The following is a description of a gene set: The regulation of the rate of heart contraction mediated by chemical signaling, hormonal, autocrine or paracrine. Mouse Gene Set: GOBP_REGULATION_OF_HEART_RATE_BY_CHEMICAL_SIGNAL studied in species Mus musculus, and this is the list of marker genes: Tpm1, Chrm3, Srebf1, Nos1ap, Ffar3